The following is a description of a gene set: Decreased proportion of naive T cells An abnormally decreased proportion of naive T cells relative to the total number of T cells. Human Gene Set: HP_DECREASED_PROPORTION_OF_NAIVE_T_CELLS species: Homo sapiens, and this is the list of marker genes: IRF1, SASH3, PIK3R1, POLD3, FOXN1, SMARCAL1, SYK, IL2RG